Given this list of marker genes Ager, Dll4, Mmrn1, Atp2b4, Svbp, Vash1, Pik3r2, Hmgb1, Tbxa2r, Angpt4, Krit1, Hdac5, Tgfb1, Csnk2b, Map2k5, Serpinf1, Klf4, Gdf2, Rgcc, Cxcl13, S2bpcox16, Rhoa, Stard13 (StAR related lipid transfer domain containing 13), Thbs1, Adamts9, Angpt2, Gadd45a, Prl7d1, Adgrb1, Synj2bp, Mecp2, Mmrn2, Apoh (NCBI Gene Id 11818), Pdcd10, Mef2c, Stc1, Slit2, Sp100, Meox2, Pparg, Jup, Spred1, Dnaja4, Bmp10, Card10, Dcn, Notch1, Tnf (tumor necrosis factor), Fgf2, Dab2ip, Hrg, Ptprm, Robo4, Acvrl1, Patz1, Nr2f2, Itgb1bp1, Apoe, here is a description of the gene set: Mouse Gene Set: GOBP_NEGATIVE_REGULATION_OF_ENDOTHELIAL_CELL_MIGRATION Any process that decreases the rate, frequency, or extent of the orderly movement of an endothelial cell into the extracellular matrix to form an endothelium. studied in species Mus musculus